The following is a description of a gene set: Genes down-regulated in blood 7d vs 0d in children (3-17) after exposure to Fluzone/Fluarix (IIV), time point 7D. Comment: IIV (inactivated influenza vaccine) studied in species Homo sapiens BACKGROUND: In recent influenza seasons, the live attenuated influenza vaccine (LAIV) has not demonstrated the same level of vaccine effectiveness as that observed among children who received the inactivated influenza vaccine (IIV). To better understand this difference, this study compared the mRNA sequencing transcription profile (RNA seq) in children who received either IIV or LAIV. METHODS: Children 3-17years of age receiving quadrivalent influenza vaccine were enrolled. Blood samples were collected on Day 0 prior to vaccination and again on Day 7 (range 6-10days) following vaccination. Total RNA was isolated from PAXgene tubes and sequenced for a custom panel of 89 transcripts using the TruSeq Targeted RNA Expression method. Fold differences in normalized RNA seq counts from Day 0 to Day 7 were calculated, log<sub>2</sub> transformed and compared between the two vaccine groups. RESULTS: Of 72 children, 46 received IIV and 26 received LAIV. Following IIV vaccination, genes demonstrated significant differential expression at Day 7 (down-regulated). In contrast, following LAIV vaccination, genes demonstrated significant differential expression at Day 7 (5 up-regulated and 3 down-regulated). Only two genes demonstrated similar patterns of regulation in both groups. CONCLUSIONS: Differential regulation of genes was observed between 2015-16 LAIV and IIV recipients. These results help to elucidate the immune response to influenza vaccines and may be related to the difference in vaccine effectiveness observed in recent years between LAIV and IIV. Human Gene Set: COLE_BLOOD_FLUZONE_FLUARIX_AGE_03_17YO_7DY_DN from publication Cole KS, Martin JM, Horne WT, Lin CJ, Nowalk MP, Alcorn JF, Zimmerman RK (PMID 29132989), and this is the list of marker genes: CCL7, IL12B, CCL2, IFNA1, CXCL8, IL4, CXCR4